Given this list of marker genes Fos, Cotl1, Rpa2, Arpc1b, Arf5, H2-Q10, Rinl, Ubxn1, Rcn1, Epcam, Prf1, H2-Q6, Ifitm10, Calm2, H3f3b, Nkg7, Id2, Atxn1, Hnrnpd, Bcl2a1b, Arl6ip1, Bop1, Wbp11, Arpc4, Clic1, Ech1, Anxa2, Gzmm, Lgals1, Lat, Ube2m, Ccl5, Acta2, Gapdh, Dnaja2, Junb, Chmp2a, Ckb (NCBI Gene Id 12709), Ms4a4b, Ctsa, Ccdc12 (coiled-coil domain containing 12), Ndufb7, Csnk2b, Rpl13a, Cebpb, Acot7, Ybx1, Cd2, Gimap4, Gsto1, Arhgdia, Ptpn1, Cyba (cytochrome b-245, alpha polypeptide), Rab8a, Klf2, Itm2b, Igf1, Eno1b, Plaat3, Efhd2 (NCBI Gene Id 99974), Gm8369, Mgp, Vamp8, Olfml3, Myl6, Fam89b, Gimap7, Psmb3, Aspscr1, Etfb, Lgals3, H2az1, 2310033P09Rik (NCBI Gene Id 67862), Ptprcap, Casp1, Dusp1, Ctla4, Bcl3, Drap1, Serping1, Lum (NCBI Gene Id 17022), Syt11, Arl4c, Cd7, Ubb, H2-K1, Cxcr3, Sub1, Eif5a, Rab5c, Clu, Ndfip1, Rnaset2b, Fcgrt, Cenpb, Psmb8, Snrpc (U1 small nuclear ribonucleoprotein C), Tma7, Eomes, Bsg, Rgs1, Srsf5, Ccl4, Actg1, Serpina3g, Gng2, Cfl1, Ppp1ca, Sh2d2a, Lime1, Mrpl16, Lax1, Myo1f, Cd28, Glrx, Gsn, Cdc34, Baiap3, Pfn1, Thy1, Ier3, Zyx, Prr13, Psmb10, Krt14, Gnas, Calm1, Gabarap, Ubb-ps, Rac2, Myl9, H2-D1, Wbp2, Oaz1, Edf1, Chsy1, Mtch2, Arhgdib, Ppp1r18, Ywhae, S100a11, Mrpl52, Ier2, Lpxn, Cox5a, Rbm3, Fasl, Bhlhe40, Trex1 (three prime repair exonuclease 1), Cdkn1a, Fth1, Rbm4, Crip2, Prdx5, Tomm6 (translocase of outer mitochondrial membrane 6), Reep5, Cst7, Eid1, Agpat3 (1-acylglycerol-3-phosphate O-acyltransferase 3), Abhd17a, Cd3g, Tle5, Ctla2a, Limd2, Vim, AW112010, Ly6a, Gpsm3, Vmp1, S100a6, Jund, Dcn, Ybx3, Tmsb10, Pglyrp1, Krt15, Hmgb2, Lpin1, Scamp3, Hopx, Tmsb4x, Lamtor4, here is a description of the gene set: Mouse Gene Set: TABULA_MURIS_SENIS_SPLEEN_CD8_POSITIVE_ALPHA_BETA_T_CELL_AGEING from publication Tabula Muris Consortium (PMID 32669714) species: Mus musculus